Given this list of marker genes Skic3, Dcps, Exosc5, Exosc2 (exosome component 2), Exosc6, Nt5c3b, Skic2, Exosc3, Hbs1l, Skic8, Dis3, Exosc9, Exosc7, Exosc8 (exosome component 8), Exosc4, Exosc1, here is a description of the gene set: species: Mus musculus Mouse Gene Set: REACTOME_MRNA_DECAY_BY_3_TO_5_EXORIBONUCLEASE mRNA decay by 3' to 5' exoribonuclease